The following is a description of a gene set: species: Homo sapiens Human Gene Set: GOBP_PROTEIN_LOCALIZATION_TO_LYSOSOME A process in which a protein is transported to, or maintained in, a location within a lysosome., and this is the list of marker genes: GNPTG, AP3D1, PIK3C3, CLU, RAB7A, LAMTOR1, NEDD4, VPS54, NAGPA, BECN1, RRAGA, AP3M1, NCOA4, SCARB2, LMBRD1, SORL1, ATG14, GNPTAB, AP4M1, HGS, ROCK2, GPR137B, SH3BP4, PIK3R4 (phosphoinositide-3-kinase regulatory subunit 4), VPS4A, NDP, RTN4, LAPTM5, ATP13A2, LAMP2, KICS2, VPS53, KPTN, M6PR, AKT1, CD81, GCC2, HSPA8 (heat shock protein family A (Hsp70) member 8), WASH3P, RNF128, SZT2, MEAK7, AP3B1, SNX16, SORT1 (NCBI Gene Id 6272), ZFYVE16, LAMTOR4, GGA3, RRAGC, MFSD1, LAMTOR5, GLMP